Given this list of marker genes Gab1, Map3k7, Cops8, Tlr4, Lep, Ccn1, Traf6, Nox4, Psrc1, Il3, Tigar, Cimap3, Spdya, Camk1, Agt, Tnfrsf11a, Thbs1, Als2, Ect2, Tnfsf11, Notch2, Sez6l2, Rasgrp1, Abl1, Pxn, Tnf, Gpr39, Tpx2, Ang4, Map3k4, Ang6, Ern1, Pik3r5, Lrp8, Ntrk3, Ralb, Ip6k2 (NCBI Gene Id 76500), Cenpe, Itgb1bp1, Tpd52l1, Eef1a2, Csf1r, Map3k11, Zfp622, Slc1a1, Abi2, Chi3l1, Wnk4, Fbxw7, Angpt1, Ccl19-ps1, Ripk3, Ccdc88a, Dlg1, Xrcc6, Ins2, Fgf1, Ccl19-ps4, Maged1, Pdgfb, Ceacam1, Igf1, Cd4 (CD4 antigen), Npm1, Daxx, Sez6, Vegfc, Cdk5, Higd1a, Nbn, Ptk2, Ereg, Spatc1l, Fzd5, Stil (NCBI Gene Id 230631), Gprc5b, Mrnip, Map3k12, Fbn1, Agap2, Edn3, Adipoq, Traf4, Ccny, Map2k6, Tlr1, Dab2ip, Ezh2, Lmo4, Wdr24, Kit, Mre11a, Cdk5r1, Nek10, Ptprc (NCBI Gene Id 19264), Cd74, Pdgfc, Magi3, Adra2a, Ang5, Rgcc, Cemip, Map2k1, Mapk8ip3, Pik3ca, Fgfr1, Cartpt, Tcl1, Fzd8, Pim1, Hras, Tead1, Prox1, Dynap, Ccl19-ps5, Dab1, Fcer1a, Wdr59, Cd24a, Ptpn1, Irgm2, Cdc25b, Rap1a, Ccnd3, Prlr, Rhoa, Adam9, P2rx7, Ins1, Mmd2, Pibf1, Map2k3, Adcy8, Taok3, Tlr6, Ccnd2, Hmga2, Ltf, Reln, Cripto, Lilra5, Stk11, Ppp2r3c, Sez6l, Arhgef5, Nrg1, Gas6, Il4, Erbb2, Map3k5, Epha4, Unc119, Mt3, Irgm1 (immunity-related GTPase family M member 1), Snx9, Ang, Syap1, Axin1, Trem2, Fzd4, Pdcd10, Ifng, Flt1, Nrxn1, Cacul1, Egfr, Cd40, Slc11a1, Csf1, Spdye4a, Mmd, Psen1, Nedd9 (neural precursor cell expressed, developmentally down-regulated gene 9), Xrcc5, Stradb, Fgd4, Ajuba, Pdgfa, Mst1r, Fgd2, Neurl1a, Adcyap1, Tgfb2, Prkag2, Psmd10, Pik3cg, Jak2, Dok7, Ang2, Ager, Tcim, Map2k2, Zeb2, Stox1, Pde5a, Wnt3a, Slc8a2, Dstyk (NCBI Gene Id 78855), Syk, Irak1, Ddr2, Ttbk1, Ccl19-ps3, Lrrk2, Cdk5r2, Zfp91, Il1b, Snca, Kitl, Etaa1, Chrna7, Map4k2, Grem1, Htr2b, Adrb2, Tirap, Vangl2, Strada, Rapgef2, Akt1, Agrn, C1qtnf9 (NCBI Gene Id 239126), Adra2b, Epo, Ppp2ca, Sirt1, Src, Pak1, Tab2, Ntf3, Egf, Rad50, Map2k7 (mitogen-activated protein kinase kinase 7), Ddx3x, Il34, Abi1, Edn1, Tom1l1, Map2k4, Pik3r6, Drd4, Dusp19, Pdgfrb, Sesn2, Bcl10, Mtor, Fgf2, Tab1, Itgb3, Cass4, F2, Map3k1, Map3k10, Chrna3, Fgf18, Iqgap1, Wnt5a, Ccr7, Ptk2b, Clspn, Tenm1, Adam17, Tsacc, Rps3 (ribosomal protein S3), Tm9sf5, Ppia (peptidylprolyl isomerase A), Vldlr, Sash1, Adra2c, Prkcd, Card10, Dynapl1, Pih1d1, D1Pas1, Jtb, Ccnd1, Cab39, Abi3, Igtp, Mapre3, Traf2, Cib1, Ern2, Emp2, Ccl19, Kif14, Srcin1, Ccl19-ps6, Erp29 (endoplasmic reticulum protein 29), Cdkn1a, Dvl2, Insr, Map3k13 (mitogen-activated protein kinase kinase kinase 13), Efna1, Rassf2, Robo1, here is a description of the gene set: species: Mus musculus Any process that activates or increases the frequency, rate or extent of kinase activity, the catalysis of the transfer of a phosphate group, usually from ATP, to a substrate molecule. Mouse Gene Set: GOBP_POSITIVE_REGULATION_OF_KINASE_ACTIVITY